The following is a description of a gene set: from publication Cui A, Huang T, Li S, Ma A, Pérez JL, Sander C, Keskin DB, Wu CJ, Fraenkel E, Hacohen N (PMID 38057668) Mouse Gene Set: CUI_B_CELL_LTA1_B2_RESPONSE_DN Genes negatively differentially expressed in cell type: B cell upon treatment with cytokine: LT-α1/β2 in mouse lymph nodes in vivo. Cytokines mediate cell-cell communication in the immune system and represent important therapeutic targets. A myriad of studies have highlighted their central role in immune function, yet we lack a global view of the cellular responses of each immune cell type to each cytokine. To address this gap, the authors created the Immune Dictionary, a compendium of single-cell transcriptomic profiles of more than 17 immune cell types in response to each of 86 cytokines (>1,400 cytokine-cell type combinations) in mouse lymph nodes in vivo. A cytokine-centric view of the dictionary revealed that most cytokines induce highly cell-type-specific responses. For example, the inflammatory cytokine interleukin-1β induces distinct gene programmes in almost every cell type. A cell-type-centric view of the dictionary identified more than 66 cytokine-driven cellular polarization states across immune cell types, including previously uncharacterized states such as an interleukin-18-induced polyfunctional natural killer cell state. studied in species Mus musculus, and this is the list of marker genes: H1f2, Rhob, Uba52, Jun, Ccr7, Fosb, Klf2, Klf6, Tsc22d3, Dnajb1, Cxcr4, Fos, Rgs2, Hspa1b, Septin7